The following is a description of a gene set: Genes up-regulated in comparison of mast cells versus dendritic cells (DC). species: Homo sapiens In the present study we used Affymetrix oligonucleotide microarrays to produce gene transcription profiles for the major leukocyte types in humans. This comprehensive dataset enabled us to not only establish which genes were expressed in each leukocyte type, but also which genes were expressed in each subset after activation. The used of a comprehensive dataset of gene profiles from all the major human leukocyte subsets enabled a novel and powerful means for identification of genes associated with single leukocyte subsets, or different immune paradigms. Human Gene Set: GSE3982_MAST_CELL_VS_DC_UP from publication Jeffrey KL, Brummer T, Rolph MS, Liu SM, Callejas NA, Grumont RJ, Gillieron C, Mackay F, Grey S, Camps M, Rommel C, Gerondakis SD, Mackay CR (PMID 16474395), and this is the list of marker genes: ESYT1, ZMYND8, STX3, ATP10A, OR1G1, MAGED1, HOXB9, GABRB2, NTRK1, SLC24A3, ARHGEF6, TOX, MEIS2, UBE2L3, TMEM268, ZNF175, CTCF (NCBI Gene Id 10664), EFCAB14, RHOBTB3, MON1B, LTC4S, ZNF23, RBM14, MAP7D3, NBEA, REXO5, STC2, SNRPD3, CBL, RGS9, NT5E, HECW1, PLAGL2, CSPP1, COA4, MDC1, ZNF81, PNO1, TRIO, PINLYP, NSA2, PTBP1, ZWILCH, TRIM44 (tripartite motif containing 44), MAGEC1, DYNC2H1, DEPTOR, TCF25, AMIGO2, GTF2H2B, SINHCAF, DST, RMND5A, RFX5, ITGA4, H4C11, HMG20A, RNF144A, PCDHGA3, ZNF646, CARMIL1, CCT4, CUTC, TRRAP, RETREG3, POGLUT2, PEX2, PEX3, RTL8A, TTC19, DOLPP1, DSG1, IL18R1, RPL36, STX1A, BTK, RHOH, ARHGAP6, PKMYT1, ANKRD28, BCL2L2, RPLP1, PSAT1, TRA2A, GLOD4, ITGA8 (integrin subunit alpha 8), TTC31, MS4A3, FBN1, SQSTM1, FOXJ2, BRD7, LARS1, FYN, MED6, MYB, BRD8, LARP7, RPL26, TRMT9B, TRMT5, ZXDC, NCBP3, AGRP, PRKCSH, COQ10B, CCNA1, CCNB1IP1, NREP, ENSA, TSG101, CLC, CPSF7, ZCCHC24, C3AR1, GATA1 (GATA binding protein 1), RPL36AL, MAK16, CA14, OSBPL3, ZNF711, DROSHA, SAE1, AREL1, ARHGAP15, MAOB (monoamine oxidase B), TSPYL2, KIF21B, PPP4R3B, PPRC1, RPF1, EFHC2, TAL1, TMSB15B, MEFV, PNP, CD247, ARF1, IRF9, PASK, RPL6, TFG (trafficking from ER to golgi regulator), TIPRL, PCF11, WWC3, NCALD, RPL34, REN, ZNF665, KIF13B, NOX4, ANKRD27, DDIT4, LINC01278, NECAP1, TMOD1, HYOU1, ABI3BP, MED21, CFL1, HEY1, FRMPD1, FAM171A1, GRB10, RANGRF, TSC22D1, DCTN6, CIRBP, ITIH2, AKR1C4, BPI, TMEM258, USP11, ILF2, TESC, BEGAIN, TSPAN6, ASMTL, KLRG1, JADE3, SOCS2, PMP22, PPM1H, PCDH8, COLGALT2, DUSP10, PRSS2, INPP5A, ABCC1, ZNF22, PCTP, STAT3, VWA5A, PTGS2, YLPM1, LMNB1, PGBD5, NDUFB4, TRAPPC2